Given this list of marker genes SOX17, TFPI (NCBI Gene Id 7035), CBX7, NFIB, RASA4, EZR, CITED2, GADD45B, MS4A4A, TRIB1, DAPK1, ODC1, PLCE1, KLF5, RIPOR2, C1S, LEPR, ERAP1, BIRC3, GIMAP6, NAMPT, STK26, KLF2, ATF3, C1R, RBP1, EFHD1, APOL3, SMAD7 (SMAD family member 7), ACKR3, HSPA1A, KLHL2, PTGER3, PDLIM1, TNXA, GSDME (NCBI Gene Id 1687), PTCH1, NDRG1, KLF4, GATA2, ABLIM1, CXADR, ADH1B, PLAAT4, LTBP1, MOXD1, HOXA5, MAP3K5, NR3C1, MAFF, ADD3, GSTM5, PHYHIP, RARRES2, HIVEP2, PAWR, ABCA8, WFS1, GSAP, IER2, MDFIC, MSX1, NR4A2 (NCBI Gene Id 4929), BCL6, RTN3, EGR1, ADIRF, here is a description of the gene set: studied in species Homo sapiens Genes down-regulated in uterine fibroids vs normal myometrium samples. Uterine fibroids are some of the most common tumours of females, but relatively little is known about their molecular basis. Several studies have suggested that deletions on chromosome 7q could have a role in fibroid formation. We analysed 165 sporadic uterine fibroids to define a small 3.2 megabase (Mb) commonly deleted region on 7q22.3-q31.1, flanked by clones AC005070 and AC007567. We also used oligonucleotide microarrays to compare the expression profiles of 10 samples of normal myometrium and 15 fibroids, nine of which displayed 7q-deletions. Activating transcription factor 3, patched homolog (Drosophila), homeo box A5, death-associated protein kinase 1, and retinoic acid receptor responder 3 were downregulated, and excision repair crosscomplementing 3, transcription factor AP-2 gamma and protein kinase C beta 1 were upregulated in fibroids. New pathways were discovered related to fibroid formation. The presence or absence of 7q-deletions did not dramatically affect the global expression pattern of the tumours; changes, however, were observed in genes related to vesicular transport and nucleic acid binding. from publication Vanharanta S, Wortham NC, Laiho P, Sjöberg J, Aittomäki K, Arola J, Tomlinson IP, Karhu A, Arango D, Aaltonen LA (PMID 15940248) Human Gene Set: VANHARANTA_UTERINE_FIBROID_DN